The following is a description of a gene set: The compaction of chromatin into heterochromatin, a conformation that is refractory to transcription. Constitutive heterochromatin cannot be converted back to euchromatin, the transcriptionally-active conformation. In metazoa, this involves the methylation of histone H3K9. Mouse Gene Set: GOBP_CONSTITUTIVE_HETEROCHROMATIN_FORMATION species: Mus musculus, and this is the list of marker genes: Tex15, Dnmt3l, Bmi1, Atf7ip, Tdrd9, H3f3b, Mbd2, Tdrd5, Mbd3, Gm38999, Mbd1, Ddx4, Dnmt3b, Tdrd1, Rif1, Kmt2b, Fkbp6, Dnmt1, Tasor, Atrx, Mael, Tdrd12, Mov10l1, Hells, H3f3a, Mbd3l1, Dnmt3a, Cenpv, Ezh1, Smarca5, Pphln1, Ctcf, Ezh2, Setdb1, Baz2a, Kmt2a, Ehmt1, Hat1, Dot1l, Ehmt2, Sirt6, Morc2a, Piwil4 (piwi-like RNA-mediated gene silencing 4), Morc1, Bend3, Spin1, Spocd1, Dicer1, Piwil1, Ppm1d, Trim28, Hdac1, Piwil2, Smyd5, Mbd3l2, Resf1, Mphosph8